Given this list of marker genes SMARCD1, HMGA1, TSPY8, SMARCD2, ARID1A, SMYD3, H3C4, H4C11, SETD2, UBN1, H3-4, SMARCB1, ASF1B, H3C11, BRD2, RSF1, TSPY4, H1-5, H1-10 (H1.10 linker histone), PADI4, SMARCA5, TSPY2, SHPRH, TNP1, SUPT6H, H4C12, SOX9, BAZ1A, SMARCC1, CABIN1, SMARCA4, H1-4, H2BC15, H2BC10, ATAD2B, H2BC1, H4C8, SMARCE1, H4C16, H2BC7, H2BC17, DNAJC9, SMARCD3, TSPY10, H4C1, HMGB2, H3C1, KAT6A, H3C3, H3C14, HP1BP3, H3C8, H1-3, H4C5 (NCBI Gene Id 8367), H2AB3, H2AB1, NAP1L4, LIN54 (lin-54 DREAM MuvB core complex component), MCM2, H3C6, H2BC21, H3C15, SSRP1, H3C2, MCM3AP, CHAF1B, TSPYL5, H4C14, NAP1L6P, SET, H1-0, H3C7, H2BC3, H3C13, H3C10, TSPYL2, H2BC13, H1-2, TSPYL6, DAXX (NCBI Gene Id 1616), GRWD1, NAP1L3, POLE3, H3-3A, H1-9P, RBBP4, TSPY9, H4C7, TSPY3, H4C2, TSPYL4, SPTY2D1, HAT1, H2BC14, ATRX, NPM1, NAA60, KAT6B, H4C4, H2BC8 (NCBI Gene Id 8339), ANP32B, TSPY1, SMARCC2, TSPYL1, H2BC6, ASF1A, HIRA, ARID2, CHD1, NASP, H1-6, NAP1L5, H4C13, H2AB2, H2BC9, H3C12, H4C3, NFE2, H4C6, H2BC4, SART3, ATAD2, CHD2, CHAF1A, MACROH2A2, SETSIP, H3-3B, H4C15, SUPT16H, H4C9, NAP1L2, NAP1L1, H2BC11, H1-1, H1-8, H2AX, H2AC25, CHRAC1, MACROH2A1 (NCBI Gene Id 9555), here is a description of the gene set: A process that is carried out at the cellular level which results in the assembly, arrangement of constituent parts, or disassembly of one or more nucleosomes. Human Gene Set: GOBP_NUCLEOSOME_ORGANIZATION species: Homo sapiens